The following is a description of a gene set: from publication Chen Y, Wang X (PMID 31504780) Mouse Gene Set: MIR_7051_5P studied in species Mus musculus Genes predicted to be targets of miRBase v22 microRNA mmu_miR_7051_5p in miRDB v6.0 with MirTarget v4 prediction scores > 80 (high confidence targets)., and this is the list of marker genes: Igsf9b, Uck2, Rnf185, Fads1, Chmp1a, Zmynd8, Zbtb37, Sec61a2, Cyp2ab1, Chd2, Ssh2, Tyw1, Tnpo3, Kctd15, Ksr2, Epha10, Primpol, Zfpm2, Gtf3c5, Lox, Ppp6r2, Dcbld1, Ppp1r10, Bhlha15, Mlec, Septin5, Susd6, Lasp1, Manba, Snai2, Lgr4, Serpina3k, B4galnt1, Crocc2, Mecp2, Cpne8, Chek1, Ppp1r16b, Gmip, Hadha (hydroxyacyl-CoA dehydrogenase trifunctional multienzyme complex subunit alpha), Stxbp6, Gpr26, Nectin1, Nrros, Dab2ip, Rtf2, Lrrc55, Vars2, Slc35f1, Adamts1, Zfp512b, Insyn2b, Mtrr, Grik5, Cldnd1, Dag1, Tbx21, Zzz3, Mmp2, Shisa7, Dhx36, Itgb1, Acvr1c, Zfp37, Serpina3c, Plekhm3, Kat6a, Rab11fip3, Dgkd, AU022252, Txndc9, Zfp36, Palm, Slc7a9, 1600012H06Rik, Dixdc1, Vwa2, Aacs, Rnf40, Nfatc4, Abhd4, Hapln4, Oprl1, Mapre2, Pim3, Mier3, Sspn, Nmb, Prkacb, Diablo